Given this list of marker genes IQCA1, LRRC34, APCDD1L, GTF2A1L, ZNF875, CFAP410, EPHA5 (EPH receptor A5), FERD3L, EIF2D, DIPK2B, GBGT1, HSPB9, DYSF, GALNT15, BOD1, BCOR, SLC35C2, TWIST1, PRLHR, SH3D21, RGMA, TPPP3, RIC3, HOXD12, ALDOC, EFCAB6, HPDL, JPH2, TGFB1I1, MLH3, SLITRK4, ADAMTS17, OSM, SUFU, EXOC6, BEGAIN, PRRC1, ZFP69, SLC47A1, KCNA4, ARRDC3, GABRQ, TCF21, ZDHHC11, DRD4, UHRF1, DOK7, VWC2, ISYNA1, RALBP1, MEPCE, RNF152, GRM7, NLRC3, ADIPOR2, TMEM150A, OAZ2, RETREG1, FUCA2, ECHDC1, GIPC2 (NCBI Gene Id 54810), KCNH7, TSHR, BANP, UPB1, TACR3, CARD9, TEX26, EIF4EBP3, AOX1, CPPED1, LHPP, PRTN3, HAAO, LRRC61, ZNF671, DYDC2, CANX, HDAC7, ANKS1B, MARVELD1, SLC46A3, SVIL, RSPO2, PNMT, NOS3, CMTM2, CSMD1, POU4F2, RGN, TFAP2A, RASGRP2, ZMYM6, RCSD1, PKP1, TMEM101, OTOP2, CLEC1A, IRF4, ZNF22, TRPV4, CNBP, ZNF626, SYNGR3, TYMP, CST6, LRIG1, CLMP, CAVIN1, PHKG1, FBXO39, LDLRAD4, HOXD13, LRRC71, ACOT12, BCAS2, PLEKHF2, ARHGAP22, FBLIM1, RYR3, AMT, REC8, SPOCK2 (SPARC (osteonectin), cwcv and kazal like domains proteoglycan 2), NID2, ARHGEF1, AJAP1, FBP1, ATP8A2, MOS, SLC22A3, RASGRP1, BNC1, TBXT, C1QTNF1, RAPGEF4, SLC4A11, PRDM8, ST6GAL2, LIMD2 (NCBI Gene Id 80774), AMIGO3, ATP2A2, GAL3ST1, GRK2, ZCCHC24, HNF1B, AGTR1, IGFBP4, LCK, MMRN2, PAPOLB, SLC5A7, RAPGEFL1, COL1A2, PAX1, NEFL (neurofilament light chain), CACNA2D2, HOXD3 (homeobox D3), HOXA7, SH3YL1, SOX1, TMEM179B (NCBI Gene Id 374395), MEDAG, TLL2, PCDHGA3, FGF11, WT1-AS, CIDEB, TMEM74B, NFAM1, SARM1, NKAIN4, SCARF2, PNMA1, CCDC140 (CCDC140 long non-coding RNA), ESX1, KCNJ3, VPS9D1, GIMAP8, GABRA2, VAMP5, SLCO4A1, LSP1, PAM, SPAG6, BTG3, ANK2 (NCBI Gene Id 4028), IL16, NECAB1, DPEP3, GCKR, ZNF177, ST6GALNAC3, CLXN (calaxin), ACP1, CD81, GRIN2A, TGFBI, CCDC86, PROM1, STK32B, EXOC7, KCNC4, SLC6A2, LRFN5, CNNM1 (cyclin and CBS domain divalent metal cation transport mediator 1), PARP6, MRAP2, HOXC12, IGF2-AS, NHLH2, SNX6, COL1A1 (NCBI Gene Id 4970), HOXA13, PCDHGC4, ELAVL2, KIT, ISL1, SULF2, TAGLN, MAP4K3, COG1, SLC27A6, ESR1, CADPS, CYP2W1, ANGPTL2, GNA14, CNN1, PROP1, FRZB, UCN, FECH, CXCL12, OLFM1, PYGO1, FGF4, ADIRF, TF (transferrin), SLC29A2, L1TD1, SLIT2, TNFRSF10C, ZNF454, CNIH3, BRD9 (NCBI Gene Id 65980), AHI1, TACR1, ME3, UNKL, POU2AF1, VWCE, ZNF785, PLTP, TBX20, PAX9, HSPB6, KRT72, CSTF2T, DUOX1, MT1E, LHX1, TRIP6, ID4, CSF1, PDLIM1, GP1BA, HOXA9, POLH, SLC26A9, CCDC87, SNX33, IZUMO1, ACTB, NEFM, SYT10, ZBTB47, SECTM1, PRXL2A, TMSB10, RSPH6A, KL, DIO3OS, ZNF154 (zinc finger protein 154), PHF3, TMPRSS12, TMED2, ADAM30, SEC31B, FAF1, ALX1, SLC17A6, PIK3R5, ADGRD2, NELL1, DAZAP1, PENK, ZNF513, RINL, CYP27A1, SOWAHA, CACNA1C, HOXB4, MAL, P2RY11, ADRA1A, OTOF, ZIM2, ITPKB, PDE4DIP, NAGS, TRAF5, DAB2IP, ZNF534, HPN, LDOC1, PDE8B, PLCB2, CD300A, ENPP2, TMPRSS6, CCDC62, HCN4, C3orf62, PCDHGB2, NME4, DLC1, LYL1, KDM1A, FAM83F (family with sequence similarity 83 member F), INSRR, HTR5A, COL5A1, CD93, ZNF428, TMEM204, ZFP69B, GRID2, SLC49A3, SPESP1, CPT1B, KIF12, NCL, GDI1, DPH7 (diphthamide biosynthesis 7), GFOD1, DTNB, BCAT1, RBBP6, YPEL3, CDH13, RARRES2, NFIX, ZNF22-AS1, DYRK1B, GFPT2, HLX, LXN, VPREB1, LIN28A, CYYR1, CA7, COPZ2, SLAMF1, CNTNAP5, COL2A1, GATA3 (GATA binding protein 3), FAM107A, PRSS50, ETV7, MINDY3, JPH1, ADAMTSL4, RARB, XPO5, ANKLE1, LRRC3B, ABCG4 (ATP binding cassette subfamily G member 4), here is a description of the gene set: studied in species Homo sapiens Human Gene Set: HATADA_METHYLATED_IN_LUNG_CANCER_UP from publication Hatada I, Fukasawa M, Kimura M, Morita S, Yamada K, Yoshikawa T, Yamanaka S, Endo C, Sakurada A, Sato M, Kondo T, Horii A, Ushijima T, Sasaki H (PMID 16407832) Genes with hypermethylated DNA in lung cancer samples. DNA methylation in the promoter region of a gene is associated with a loss of that gene's expression and plays an important role in gene silencing. The inactivation of tumor-suppressor genes by aberrant methylation in the promoter region is well recognized in carcinogenesis. However, there has been little study in this area when it comes to genome-wide profiling of the promoter methylation. Here, we developed a genome-wide profiling method called Microarray-based Integrated Analysis of Methylation by Isoschizomers to analyse the DNA methylation of promoter regions of 8091 human genes. With this method, resistance to both the methylation-sensitive restriction enzyme HpaII and the methylation-insensitive isoschizomer MspI was compared between samples by using a microarray with promoter regions of the genes. The reliability of the difference in HpaII resistance was judged using the difference in MspI resistance. We demonstrated the utility of this method by finding epigenetic mutations in cancer. Aberrant hypermethylation is known to inactivate tumour suppressor genes. Using this method, we found that frequency of the aberrant promoter hypermethylation in cancer is higher than previously hypothesized. Aberrant hypomethylation is known to induce activation of oncogenes in cancer. Genome-wide analysis of hypomethylated promoter sequences in cancer demonstrated low CG/GC ratio of these sequences, suggesting that CpG-poor genes are sensitive to demethylation activity in cancer.